The following is a description of a gene set: Human Gene Set: MIR1227_3P Genes predicted to be targets of miRBase v22 microRNA hsa-miR-1227-3p in miRDB v6.0 with MirTarget v4 prediction scores > 80 (high confidence targets). species: Homo sapiens from publication Chen Y, Wang X (PMID 31504780), and this is the list of marker genes: CKAP5, HIC1, SNX19, ZNF705D, DDX3X, PREX2, C4orf17, OSBPL6, CCNT2, ACBD7 (acyl-CoA binding domain containing 7), PDXDC1, GNB1, DKK1, TMEM212, FBXL3, SHTN1, AGAP1, MOB4, RAB4A, CADM2, KLK13, GPC6, LSM1, PNRC1, ZBTB5, SECISBP2L, ZNF766, SLC2A12, TAF4, SNAP91, ACBD4, ODF2L, RLIM, OPN3, TCEAL1, WTAP, PRKAB2, PTGER4, CLN8, DOCK9, GSG1, TET2, MAB21L3, GPD2, FAM91A1 (NCBI Gene Id 157769), PDAP1, ARID4B, ZNF521, HBS1L, CX3CR1, ATP6V1B2 (ATPase H+ transporting V1 subunit B2), DYNLT1, IRF2, HOXC6, CSRNP3, AVL9, VEZT, PNKD, LYPD3, LRP10 (LDL receptor related protein 10), TAOK1, PTGFRN, ADAM10, AKAP14, COX20, CLOCK (clock circadian regulator), USP9X, FAM241B, SSH1, MYLIP, FRY, MAT2B, TGFBR1, GPLD1, ZNF616